The following is a description of a gene set: Mouse Gene Set: GOBP_AMINO_ACID_TRANSPORT The directed movement of amino acids, organic acids containing one or more amino substituents, into, out of or within a cell, or between cells, by means of some agent such as a transporter or pore. species: Mus musculus, and this is the list of marker genes: Slc25a2 (NCBI Gene Id 83885), Slc1a3, Sfxn4, Arl6ip1, Slc7a8, Slc7a15, Il1rn, Slc6a2, Slc13a3, Slc66a1, Lrrc8c, Grm7, Slc36a3, Grm2, Sv2a, Slc7a9 (solute carrier family 7 (cationic amino acid transporter, y+ system), member 9), Adora2a, Slc38a10, Grm1, Slc16a2, Slc6a16, Ttyh3, Kcnk1, Slc25a13, Slc7a2, Abat, Slc6a18, Slc43a2, Slc38a1, Slc22a2, Slc1a1 (NCBI Gene Id 319379), Lrrc8b, Slc6a15, Slc6a9, Lep, Slc7a1, Slc22a15, Slc38a9, Sfxn2, Htr1a, Slc1a5, Pianp, Slc7a5, Gabbr1, Rab3gap1, Kmo, Slc25a15, Slc25a38, Epm2a, Gipc1, Slc7a12, Ace2 (angiotensin converting enzyme 2), Slc6a13 (NCBI Gene Id 14412), Nat3, Trpv1, Slc1a7, Myc, Avp, Slc25a26, Sfxn3, Cacnb4, Arg1, Vps54, Arl6ip5, Abcc8, Slc25a18 (solute carrier family 25 (mitochondrial carrier), member 18), Ttyh1, Slc7a10, Slc15a1, Gja1, Slc6a19, Htr1b, Pdpn, Snca, Dpysl2, Lrp5, Npy5r, Slc7a11, Gnat2, Slc6a17, Ctns, Lrrc8d, Hrh3, Slc25a22, Itgb1, Htr6, Rgs2, Slc7a4, Slc6a8, Slc25a29, Slc6a14, Slc6a20a, Apba1, Avpr1a, Slc1a4, Slc3a2, Cln8, Syt4, Cacna1a, Nherf1, Slc22a4, Lrrc8a, Sfxn5, Kcnj8, Slc32a1, Kcnk2, Slc6a3, Slc16a10, Prkcd, Cln3, Slc17a8, Slc47a1, Slc36a1, Slc1a2, Nfkbie, Slc1a6, Tnf, Slc7a7, Stxbp1, Kcnj10, Cltrn, Slc11a1, Htr2c, Slc38a8, Bdnf, Slc17a7, Mfsd12, Dtnbp1, Arg2, Slc38a3, Slc38a2, Trpc4, Slc7a13, Trh, Slc36a4, Nr3c1, Slc6a21, Slc36a2, Slc43a1, Slc7a6, Myo6, Ntsr1, AU018091, Ttyh2, Slc15a4, Ucp2, Gfap, Sfxn1, Slc7a3, Xk, Lrrc8e, Llgl2, Slc6a5, Slc25a12, Nfe2l1, Slc3a1, Agt, Nf1, Rgs4, Adora1, Slc6a11, Slc7a14, Slc6a4, Per2, Slc6a1, Slc6a6, Slc38a4, Psen1, Slc17a6, Slc38a11, Tspo2, Best1, Slc38a7, Grin2b, Prkg1, Ntrk2, Slc6a20b, Il1b, Arhgef11, Slc38a6, Cck, Slc6a7, Septin2, Pak1, P2rx7, Slc12a2, Slc17a5, Slc38a5, Grik1, Slc6a12, Slc25a44